Given this list of marker genes GNAQ, PRKCA, THBD, GP6, SYK, IL6, CEACAM1, HRG, ADGRG1, NOS3, PRKCD, IL6ST, UBASH3B, PLA2G4A, PEAR1, PDGFRA, SERPINE2, CTSG, C1QTNF1, TLR4, FUNDC2, CELA2A, IL6R, FLNA, FCER1G, VPS33B, SVEP1, TEC, PDPN (podoplanin), EMILIN1, CD9, TMX1, F2, MMRN1, PLEK, PDGFB, PRKG1, SH2B3, GP9, GP5, LYN, GP1BB, PRKCQ, SELP, JAK2, HTR2A, F11R, EMILIN2, GP1BA, PTPRJ, MFSD2B, PDGFA, ADAMTS18, ALOX12, APOE, here is a description of the gene set: Any process that modulates the rate or frequency of platelet activation. Platelet activation is a series of progressive, overlapping events triggered by exposure of the platelets to subendothelial tissue. Human Gene Set: GOBP_REGULATION_OF_PLATELET_ACTIVATION studied in species Homo sapiens